The following is a description of a gene set: studied in species Mus musculus Mouse Gene Set: GOBP_CELLULAR_RESPONSE_TO_GAMMA_RADIATION Any process that results in a change in state or activity of a cell (in terms of movement, secretion, enzyme production, gene expression, etc.) as a result of a gamma radiation stimulus. Gamma radiation is a form of electromagnetic radiation (EMR) or light emission of a specific frequency produced from sub-atomic particle interaction, such as electron-positron annihilation and radioactive decay. Gamma rays are generally characterized as EMR having the highest frequency and energy, and also the shortest wavelength, within the electromagnetic radiation spectrum., and this is the list of marker genes: Trex1 (NCBI Gene Id 22040), Atr, Ddias, Cdkn2a, Trp53, Zmpste24, Cryab (crystallin, alpha B), Gtf2h5, Xrcc6, Mdm2, H2aj, Kdm1a, Rpl26, H2ax, Hsf1, Rnf4, Atm, Yap1, Hras, Tmem109, Egr1, Wrn, Bcl2l1, Rad51, Chek2, Map3k20, Elk1, Xrcc5, Tlk2, Cdkn1a, Tspyl5